Given this list of marker genes AHSP, BAX, LYN, KMT2E, TGFBR3, ACIN1, ALAS1, HIPK2, ETV2, MYB, KCNQ1, ZFPM1, DIAPH3, EPO, INPP5D, FOXP3, NCKAP1L, G6PD, SLC25A40, FCAR, BMP4, KLF1, HIF1A, TRIM58, STAT5B, SRF, CHMP5 (charged multivesicular body protein 5), PTPN2 (protein tyrosine phosphatase non-receptor type 2), BTK, SLC1A5 (solute carrier family 1 member 5), RPS24, FOXO3, PRMT1, L3MBTL3, GATA3, ITPKB, SCNN1B, VEGFA, HEATR3, ATP5IF1 (ATP synthase inhibitory factor subunit 1), MAFB, KLF13, RAC1, RHEX, ABCB10, ID2, IREB2, TMOD3, ARID4A, MFHAS1, ZBTB7A, FCER1G, BAP1, XKR8, TRIM10, ACVR2A, HMGB1, HSPA1B, HMGB2, NF1, ADAM17, RHAG, HSCB, NCAPG2, JMJD6 (jumonji domain containing 6, arginine demethylase and lysine hydroxylase), SENP1, FAM3D, SLC25A38, P4HTM, STAT3 (NCBI Gene Id 6774), GATA2, EPAS1, SLC4A1, THRA, BBIP1, HBZ, JAM3, MPL, HCLS1, GATA1, RCOR1, HMOX1, ALAS2, ADAR, NFE2L1, SOD1, SPI1, SMAP1, TMEM14C (NCBI Gene Id 51522), KLF2, PIK3CB, RPS17, CASP3, STAT1, BCL6, TCEA1, HOXB6, CITED2, TSPAN9, ANKRD54, PRKDC, CEBPG, TRAF3IP2, MIR221, CDIN1, BPGM, SLC11A2, SP3, INHBA, ANXA1, PRDX1, FLVCR1, SELENOW, RACGAP1 (Rac GTPase activating protein 1), IKZF1, HSPA1A, ZNF16, HNRNPU, UBA5, CSF1, SLC48A1, MPIG6B, ERCC2, TAL1, CDK5RAP3, PKNOX1, BCL2L11, ARNT, TSPO2, MAEA, RPS19, EPB42, KITLG, GCNT4, MTHFD1, RAC2, SMAD5, DYRK3, ZFP36L1, BBS4, LDB1, ZFP36, SLC15A4, IL6, HDAC6, YPEL4, SLC25A5, ETS1, BRD1, FAM210B, MAPK11, UFL1, ADGRF5, SH2B3, INHA, LYAR, MED1, DNASE2, MAPK14, HOXA5, PIK3CD, MIR486-1, DMTN, MIR222, PTBP3, ISG15, RB1, JAK2, CCR2, PLA2G10, CDK6 (NCBI Gene Id 1021), FECH, MB, MERTK, HCAR2, AXL, PDE4B, B2M, SLC7A11, RPS14, LIPA (NCBI Gene Id 3988), NEMP1, NCSTN, KAT7, ACVR1B, GPI, BAK1, STAT5A, HSPA9, SFXN1, KIT, VPS13A, GLUL, here is a description of the gene set: The process of regulating the proliferation and elimination of myeloid cells such that the total number of myeloid cells within a whole or part of an organism is stable over time in the absence of an outside stimulus. studied in species Homo sapiens Human Gene Set: GOBP_MYELOID_CELL_HOMEOSTASIS